Given this list of marker genes Sh2b2, Frs2, Stap1, Sh2b1, Gab2, Frs3, Sh2d3c, Irs2, Dok2, Tradd, Irs1, Shc1, Grb2, Sh2b3, here is a description of the gene set: Mouse Gene Set: GOMF_TRANSMEMBRANE_RECEPTOR_PROTEIN_TYROSINE_KINASE_ADAPTOR_ACTIVITY The binding activity of a molecule that brings together a transmembrane receptor protein tyrosine kinase and one or more other molecules, permitting them to function in a coordinated way. studied in species Mus musculus